The following is a description of a gene set: Neighborhood of PSMC2 proteasome (prosome, macropain) 26S subunit, ATPase, 2 in the MORF expression compendium Human Gene Set: MORF_PSMC2 Neighborhood of PSMC2 species: Homo sapiens, and this is the list of marker genes: VCP (NCBI Gene Id 94731), ADAR, COX5A, SRP9, KIF2A, PSMB4, URM1, MYL11, PPP2R5E, HSBP1, RPP38, HNRNPAB, NEDD8, GLG1, SHMT1, FAM120A, RAD21, SPCS2, POLR3C, PRMT1, SMG7, COIL, DPM1, DNPEP, SEC61B, EIF5, BAG5, DUSP11, EIF4H, C6orf62, SUMO1, CLEC18C, SDHC, YWHAB, RAD23B, UBXN4, SKP1, GTF2H1, ZZZ3, CNIH1, TMED2, RAC1, BANF1, ATP5MF, HARS2, COPB2, COX7A2L, FAM20B, G3BP1, RAB11A, MBD4, PSMA3, RER1, DLD, SEM1, CFDP1, CLN3, RAB9A, TIAL1, NCBP2, PSMC2, ARCN1, SEC13, CNBP, PSMC1, KARS1, SYPL1, PITPNB, ENSA, PIGC, PUF60, PEX11B, ATP6AP2, ATP6V1F, EBAG9, ARF5, DRG1, BUD31, PSMD7, COPS5, SP3, RNF6, BCAP31, IK, METAP1, ETFA, CANX, SRP19, ATP6V1H, URI1, IST1, RAE1, GMFB, UBA1, XPC, MORF4L2, UBR5, RAB5A, COPB1, PSMC6, COX4I1, KHDRBS1, XPA, FUBP1, BZW1, HTATSF1, ZNF410, PPP1R7, RAB1A, SEC61G, PGRMC1, STX4, PDCD6 (programmed cell death 6), MTDH, RPL36AL